Given this list of marker genes Mybbp1a, Rptor (regulatory associated protein of MTOR, complex 1), Ar, Sf3b1, Inhba, Chd8, Dek, Brf1, Foxa2, Zc3h8, Ice2, Baz1b, Ercc6, Mtor, Ddx21, Ell, Ice1, Smarca5, Myo1c, here is a description of the gene set: Any process that activates or increases the frequency, rate or extent of transcription mediated by RNA polymerase III. Mouse Gene Set: GOBP_POSITIVE_REGULATION_OF_TRANSCRIPTION_BY_RNA_POLYMERASE_III species: Mus musculus